Given this list of marker genes ART5, SIRT6, ART1, ARF4, ART4, ART3, here is a description of the gene set: species: Homo sapiens Catalysis of the reaction: L-arginyl- + NAD+ = H+ + (ADP-D-ribosyl)-L-arginyl- + nicotinamide. Human Gene Set: GOMF_NADPLUS_PROTEIN_ARGININE_ADP_RIBOSYLTRANSFERASE_ACTIVITY